Given this list of marker genes Trmt112, Bop1, Rbm34, Ddx18, Rpl7, Znhit3, Nop2, Nol9, Rpl7a, Pak1ip1, Las1l, Rpl7l1, Ftsj3, Rrp15, Ppan, Mak16, Nsa2, Pes1, Rpf1, Urb1, Wdr12 (WD repeat domain 12), Znhit6, Npm1, Gtpbp4, Rpl35, Eif6, Rpf2, here is a description of the gene set: Any process involved in the maturation of a precursor Large SubUnit (LSU) ribosomal RNA (rRNA) molecule into a mature LSU-rRNA molecule. Mouse Gene Set: GOBP_MATURATION_OF_LSU_RRNA studied in species Mus musculus